Given this list of marker genes Qprt, Slc25a51 (NCBI Gene Id 77670), Nampt, Afmid, Ido1, Naprt, Kmo, Nmnat2, Haao, Nmnat1, Ido2, Kynu, Aspdh, Nmrk2, Nmnat3, Nmrk1, Nadsyn1, here is a description of the gene set: species: Mus musculus The chemical reactions and pathways resulting in the formation of nicotinamide adenine dinucleotide (NAD+), a coenzyme that interconverts with its reduced form, NADH, in many redox and catabolic reactions. NAD+ is derived from various sources including vitamin B3. Mouse Gene Set: GOBP_NAD_BIOSYNTHETIC_PROCESS